The following is a description of a gene set: studied in species Homo sapiens Genes up-regulated in HMC-1 (mast leukemia) cells: untreated versus incubated with the peptide ALL1. from publication Baram D, Dekel O, Mekori YA, Sagi-Eisenberg R (PMID 20190146) Human Gene Set: GSE19888_CTRL_VS_A3R_INHIBITOR_TREATED_MAST_CELL_UP We demonstrate that the G protein Gi3 is the cellular target of the adenosine A3 receptor (A3R). By using a cell permeable peptide comprising the C-terminal end of Gαi3 fused to an importation sequence (ALL1) as a selective inhibitor of Gi3 signaling, we show that by coupling to Gi3, the A3R stimulates multiple signaling pathways in human mast cells, leading to upregulation of cytokines, chemokines and growth factors.Following contact with activated T cell membranes, endogenous adenosine binds to and activates the A3R, resulting in Gi3-mediated signaling. Specifically, the majority of ERK1/2 signaling initiated by contact with activated T cell membranes, is mediated by Gi3, giving rise to ALL1-inhibitable cellular responses. These results unveil the physiological GPCR that couples to Gi3 and establish the important role played by this G-protein in inflammatory conditions that involve adenosine-activated mast cells. We used microarrays to detail the effect of ALL1 on gene expression of HMC-1 cells activated directly by the A3 receptor, or by contact with activated T cell membranes., and this is the list of marker genes: ICMT, PAXIP1 (PAX interacting protein 1), MYO19, MGME1, XRCC5, ARV1, FARSB, PSAT1, PRORP, ALG5, CISD3, HINT2, LAPTM4B, TFRC, CDT1, GSTZ1, SRSF3, SNUPN, HCFC1, POC1A (POC1 centriolar protein A), SSNA1, DIAPH3, HSDL2, SLC27A2, PRADC1 (NCBI Gene Id 84279), KIF20A, SKA3, FAM111A, MFNG, RNF138, EXO1, HYCC1, BRCA2, ATP5MC3, C4orf46, NDUFB8, C1RL, MYBL2, SPC24, SUV39H2, RPS27L, MRPL16, HAX1, FAM111B, BCAT2, DPAGT1, IKZF4, NDUFB4, CSE1L, DPF3, ALG10, DCLRE1B, NDUFA8, ATPAF2, ARHGEF39, ZWILCH, ANKRD35, TMEM177, MRPL37, COL9A2, HOXB7, MDH1, SAPCD2, SLC12A8, AARS1, COQ3, KPNA2, SNRPB, MPV17, ZDHHC12, SNRPF, TMEM237, CCNB2, LSM10, MLLT11, CDH17, UQCC4, MFAP1, MAL, TBRG4, HMOX2, METAP2, SAPCD1, NDUFA9, GALK1, LILRP2 (NCBI Gene Id 79166), EME1, TOX2, LRRC58, MYH10, E2F2, ATP5MG, PLK1, H3C7, SMTN, ZDHHC13, C21orf58, CEP57L1, ERI1 (NCBI Gene Id 90459), CKAP2L, IFI27L2, DHPS, CKLF, CEACAM1, DYNC2I2 (NCBI Gene Id 89891), CCR6 (C-C motif chemokine receptor 6), CCDC167, CDC25A (NCBI Gene Id 993), ULBP2, CCNF, SUOX, PLGRKT, DNAH14, HAT1, TCF19, RRP36, ZNF254, ERAL1, HNRNPF, DBI, MRPL44, NSD2, COMTD1, CHEK2, MRPL13, MRPL12, LSM4, SPRTN, CDK2, C3orf18, DLAT, ZNF382, MTLN, MMP25, ARHGAP11A, ANKRD36B, LRP8, PGBD1, DYNLRB1, CDCA2, POLR2K, GLE1, RPF2, MSMO1, POLA2, HNRNPD, TMEM214, LRP11, EGFL6, BTBD6, TXLNA, REXO5 (NCBI Gene Id 81691), TMEM97, HNRNPAB, GALE, CCDC28B, KLHL23, NRM, E2F7, ACADM, MTHFD1, MICB, EIF2B1, LZIC, CLN6, CHID1, KIFBP, MTAP, HAUS8, EIF2S2, CEP170B, HMBS, PUSL1, TPGS2, STIL, TTI2, COMMD7, FANCC, COQ9, ITPA, SLCO4A1, MRPL34, SF3B5, JHY, SNRPA, KNTC1, ROMO1, WDR5, TMEM14A, COX5B, HSPA14, MCM2, GGCT, KIF20B, GEN1, PPCDC, ARL2BP, EXOSC9, MZT1, RANBP1